The following is a description of a gene set: species: Homo sapiens Human Gene Set: GOMF_LIPID_TRANSFER_ACTIVITY Removes a lipid from a membrane or a monolayer lipid particle, transports it through the aqueous phase while protected in a hydrophobic pocket, and brings it to an acceptor membrane or lipid particle. This results in intermembrane transfer of lipids., and this is the list of marker genes: PRELID3A, CETP, TSPO, C2CD2L, PRELID1, GRAMD1B, APOB, PLEKHA8, APOA2, OSBPL6, ABCG8, OSBPL3, TNFAIP8L3, OSBP, CIDEA, SCP2, ABCG5, TRIAP1, ABCA1, GRAMD1A, STARD5, CLN3, CPTP, STAR, GLTP, ESYT1, CERT1, OSBPL2, APOA4, GRAMD1C, NPC2, PITPNM1, PITPNC1, OSBPL1A, ABCA3, PITPNA, PRELID3B, APOA5, PLTP (NCBI Gene Id 5360), STARD4, ATG2A, GLTPD2, ATG2B, OSBPL8, APOA1, STARD7, TMEM63B, STARD3, NPC1, MTTP, PLEKHA8P1, CIDEB, TTPA, BLTP1, OSBPL7, ARV1, PRELID2, ABCG1, BLTP3B, PITPNB, PITPNM2, APOE, OSBPL5, PITPNM3, CIDEC, OSBPL9